The following is a description of a gene set: Any process that modulates the frequency, rate or extent of proton transport into, out of or within a cell, or between cells, by means of some agent such as a transporter or pore. studied in species Mus musculus Mouse Gene Set: GOBP_REGULATION_OF_PROTON_TRANSPORT, and this is the list of marker genes: Tcirg1, Sco1, Atp7a, Cox17, Atp4b, Slc36a2 (solute carrier family 36 (proton/amino acid symporter), member 2), Phb2, Sphk2, Taco1 (NCBI Gene Id 70207), Atp4a, Nr3c2, Il4, Ndufa4, Slc9a6, Ppif, Il13, Coa8